The following is a description of a gene set: species: Mus musculus The process in which the migration of an axon growth cone of a motor neuron is directed to a specific target site in response to a combination of attractive and repulsive cues. Mouse Gene Set: GOBP_MOTOR_NEURON_AXON_GUIDANCE, and this is the list of marker genes: Epha4, Sema3a, Alcam, Chn1, Cxcr4, Lmo4, Sema3f, Ark2c, Ntn5, Erbb2, Hoxa1, Egr2, Nog, Slit1, Mnx1, Foxp1, Nrp1, Cxcl12, Plxna4 (NCBI Gene Id 330281), Hoxa2, Epha3, Cdk5, Lhx4, Lhx1, Rac1, Slit2 (slit guidance ligand 2), Ntn3, Mycbp2, Kif5c, Etv4, Rac3, Lhx3, Fgf8, Ntn1, Plxna3